The following is a description of a gene set: from publication Chen Y, Wang X (PMID 31504780) Genes predicted to be targets of miRBase v22 microRNA hsa-miR-6749-3p in miRDB v6.0 with MirTarget v4 prediction scores > 80 (high confidence targets). studied in species Homo sapiens Human Gene Set: MIR6749_3P, and this is the list of marker genes: CLOCK, FAM131A, NTRK2, DAG1, ATXN7, BICD2, XBP1, SV2B, NYAP1, ORC5, NBEA, PID1, SNX27 (sorting nexin 27), DHFR, GDF6, FOXK1, VTA1, BTBD9, CTU1, SHISA6, XKR8, ZCCHC2, BAHD1, BRINP1, CHD3, PPP3R2, SENP6 (NCBI Gene Id 26054), PDE12, LINC03042, TRHDE, ICOSLG, NSD1, ZNF468, HCFC1, SORCS3, RIOK3, KLF3, DIO2, WDR91, UBN2, RBM15, PRDM6, FOS, RHOB, ARMH3, PTPRJ, DMRTB1, CACNA1C (NCBI Gene Id 775), CPLX2 (NCBI Gene Id 84242), ZNF629, GJA5, TNRC6B, VTCN1, NFASC, S100A5, GOLT1A (golgi transport 1A), PPP1R3E, BLTP3A, DOK7, MYO1B, NRIP3, DCAF4L2, SH3PXD2A, MIGA1, LTBR, SLC4A10, SVEP1, BLTP2, SAMD4A, RNF2, CNNM4, SFSWAP, TFE3, DNAH5, MINDY2, UBE2H, EIF4EBP2, GJB7, ARL8B, BOD1L2 (biorientation of chromosomes in cell division 1 like 2), VASH2, UGT3A1, ELOVL6, C22orf46P, ELK1, CNTNAP2, SOX12, HSD11B1L, TENM1, POP4, SPTB, GRM1, CSF2RA, BHLHE41, MEOX1, SNAI2, ARFGEF3, SESN3, JADE3, OTUD7B, SDC2 (syndecan 2), TNPO2, LYSMD4, LSAMP, KIAA0513, ABCC6 (NCBI Gene Id 5823), OSBPL6, CASTOR2, DTX3L, CDK19, NR3C1, TXNIP, THSD7B, SRF, TBC1D1, TSHZ2